The following is a description of a gene set: Human Gene Set: HP_NODULAR_CHANGES_AFFECTING_THE_EYELIDS species: Homo sapiens Nodular changes affecting the eyelids Nodular changes affecting the eyelids may have many different causes such as cystic lesions (chalaziae, hordeolae), lipogranulomas, melanomas, infectious diseases (Molluscum contagiosum) and many more., and this is the list of marker genes: EPHX2, POU2AF1, MMEL1, ABCA1, IL12A, IRF5, LDLR, G6PC1 (glucose-6-phosphatase catalytic subunit 1), PCSK9, PPP1R17, SPIB (NCBI Gene Id 6689), APOB, APOA2, EXTL3, PDE11A, TNPO3, ABCG8, PDGFRB (platelet derived growth factor receptor beta), SLC37A4, APOA1, APOE, GHR, STAT3, LPL, CYP27A1, SPRED1, PRKAR1A, IL12RB1, TTPA, TNFSF15